Given this list of marker genes Guca1a, Calm1, Ncs1, Guca2a, Calm2, Raf1, Calm3, Guca1b, Gnas, Guca2b, here is a description of the gene set: Binds to and increases the activity of an enzyme that catalyzes a ring closure reaction. Mouse Gene Set: GOMF_CYCLASE_ACTIVATOR_ACTIVITY studied in species Mus musculus